The following is a description of a gene set: Human Gene Set: KEGG_MEDICUS_REFERENCE_KEAP1_NRF2_SIGNALING_PATHWAY studied in species Homo sapiens KEAP1-NRF2 signaling pathway. Pathway ID: N00243. Pathway type: Reference. Pathway class: nt06263 Hepatocellular carcinoma. Pathway Definition from KEGG: (O2-,HO2,H2O2,OH,ACRL,4HNE,NO) -| KEAP1 -| NRF2 => (HMOX1,NQO1,GST,TXNRD1), and this is the list of marker genes: GSTA3, GSTA1, MGST1, KEAP1, HMOX1, GSTA5 (NCBI Gene Id 221357), NQO1, GSTT2B, GSTM2, GSTA2, NFE2L2, GSTM1, GSTM3, GSTO2, MGST3, GSTT1, TXNRD1, GSTT2, GSTM5, MGST2, GSTA4, GSTO1, GSTM4, GSTP1